The following is a description of a gene set: HCV Core to ERK signaling pathway. Pathway ID: N00518. Pathway type: Pathogen. Pathway class: nt06263 Hepatocellular carcinoma. Pathway Definition from KEGG: Core -| YWHA -| RAF -> MEK -> ERK species: Homo sapiens Human Gene Set: KEGG_MEDICUS_PATHOGEN_HCV_CORE_TO_ERK_SIGNALING_PATHWAY, and this is the list of marker genes: YWHAG, YWHAH, YWHAZ (tyrosine 3-monooxygenase/tryptophan 5-monooxygenase activation protein zeta), MAP2K2, BRAF, RAF1, MAPK3, YWHAQ, YWHAE, MAP2K1 (mitogen-activated protein kinase kinase 1), MAPK1, ARAF, YWHAB